Given this list of marker genes DHRS7B, KEAP1, ELOVL1, ACP5, EIF4G3, SMC4, ITGAE, M6PR (mannose-6-phosphate receptor, cation dependent), MTCH2, AHI1, ABTB2, VDAC3, TMEM187, RAB11FIP1, TALDO1 (NCBI Gene Id 6888), FANCE, RAB13, TPM4, SMARCAL1, PYCARD, TK1, TSPAN5, NTRK1, ARHGAP19, AGPAT5, LXN, CD38, ANXA5, LAMP2, POLR3K, KIF2C, CD226, STARD7, MLEC, CHMP4A, TBL2, HLA-A, ACAT1, BLM, STAP1, TMT1A, TM9SF1, ACSL5 (acyl-CoA synthetase long chain family member 5), ZMIZ1, PRDX3, SLC5A3, RDX, COL6A3, HPGDS, KPNB1, TMEM43, TPX2, ARPC2, SRGAP2, UBE2K (NCBI Gene Id 84819), TRAK1, PRCP, RAP2A, ASPM, CHST15, DOHH, RFC3, CDC20 (cell division cycle 20), PPP2R5A, POGLUT1, WSB2, CKS1B, REEP5, TXNDC9, TMEM97, TNFSF10, DCTN2, CCDC47, WDR5B, TARS1, GFI1, IMMT, CCL18, AKR1A1, ANXA2, SERPINB1, PTPN22, GORASP2, BID, PRC1, TMED5, TRAF1, CALHM2, TRIP4 (thyroid hormone receptor interactor 4), PSMA5, B2M, CD2 (CD2 molecule), PIEZO1, AURKA, MFHAS1, GNG5, KIF20A, GPALPP1, COX17, ETFDH, PAICS, CD58, SLC25A20, TGFBI, NDC80, TUBB, LSM2 (LSM2 homolog, U6 small nuclear RNA and mRNA degradation associated), ABHD5, SPATS2L, CCL22, TMEM176B, MAPKAPK3, PUDP, MRPL17, SPP1, GTF2H1, BATF, PARP1, MBOAT7, PSMD14, LGALS3, TMEM9B, DHRS1, PTGER2, PA2G4, ACOX1, TAOK3, PTTG1, HDC, DSTNP2, DAPK1, VCP, PDIA6, TRIB1, ATP6V1C1, CTNNA1, ATP6V1D, GCLM, SMARCD2, C9orf40, MAP2K3, RRM2, H2BC12, MELK, PPP1CB, CASP3, LPXN (NCBI Gene Id 9404), CASP9, IDH1, NUSAP1, GM2A, CREB3L2, BIN3, CETN3, PLAAT3, DDB2, POP7, ALDH9A1, SP110, HELLS, CNP, PAPSS1, IL27RA, NAB1, LAPTM4B, GLRX2, RAB11A, IDH2, NDUFA8, CCNB2, PPP4R1, PDE4A, CD79B, DCUN1D1, MREG, ETNK1, CFLAR, TXNDC15, RBPJ, C1GALT1C1, MYL6B, NUP62, WIPF2, POLD3, SEL1L3, CTSB, ZNF225, HMGCL, PDXK, RAB33A, SRR, B3GALT4, MAP2K4, PCLAF, RAP1GDS1, GLB1, RAD50, SEC14L1, PHTF2, GPR137B, here is a description of the gene set: Genes down-regulated in comparison of naive T cells at day 0 versus CD25+ regulatory T cell (Treg) treated with IL4 at day 10. species: Homo sapiens CD25+ regulatory T cells develop in the thymus (nTregs), but may also be generated in the periphery upon stimulation of naive CD4 T cells under appropriate conditions (iTregs). The mechanisms that regulate the generation of peripheral iTregs are largely unknown. We used microarrays to gain insights into the molecular program of extrathymic Treg development. Human Gene Set: GSE24634_NAIVE_CD4_TCELL_VS_DAY10_IL4_CONV_TREG_DN from publication Prots I, Skapenko A, Lipsky PE, Schulze-Koops H (PMID 21347372)